Given this list of marker genes Gch1, Htr1a (5-hydroxytryptamine (serotonin) receptor 1A), Crhr2, Sncb, Th, Epas1, Agtr2, Myo5a, Sult1a1, Ddc, Vhl, Ly6e, Spr, Pnkd, Itgam, Comt, Akr1b1, Npy, Moxd1, Gata3, Abat, Rtl4, Gnat2, Sncaip, Kl, Tgfb2, Cyp2d22, Agtr1a, Dao, Hand2, Park7, Rnf180, Hdc, Slitrk1, Htr2c, Slc6a3, Grin2a, Insm1, Drd1, Nr4a2, Mdga1, Aldh2, Vps35, Tacr3, Moxd2, Ednra, Maob, Chrnb2, Slc1a1, Tomt, Pnmt, Aoc2, Drd2, Sult1d1, Atp7a, Pde1b, Gpr37, Snca, Prkn, Dbh, Hprt1, Npr1, Rnls, Ndufs4, Drd4, Maoa, Mtpn, here is a description of the gene set: Mouse Gene Set: GOBP_CATECHOL_CONTAINING_COMPOUND_METABOLIC_PROCESS The chemical reactions and pathways involving a compound containing a pyrocatechol (1,2-benzenediol) nucleus or substituent. studied in species Mus musculus